The following is a description of a gene set: species: Mus musculus Mouse Gene Set: chr6G2, and this is the list of marker genes: Recql, Pyroxd1, Gm10400, Gm5051, Iapp, Capza3, Slco1a5, Cmas, Slco1a6, Gm7384, Aebp2, Slco1a1, Rpl38-ps2, 1700102F20Rik, Slco1b2, Slco1c1 (solute carrier organic anion transporter family, member 1c1), 5330439B14Rik, Gm18159, Slco1a4, Kcnj8, Abcc9, Slco1a8, Pik3c2g, Gm7457, Golt1b, Plcz1, Gys2, Spx, Gm30784, Plekha5, Rergl, Gm28523, Ldhb, Pde3a, 4930404I20Rik, 4930443G03Rik, Gm30524, Gm44156, Slco1a7, Sult6b2, Gm3961